Given this list of marker genes TXNRD2, TNFRSF11A, SLC16A1, MC2R, MRAP, PCSK1, HNF1A, PTH, CLDN16, POGZ, VDR (vitamin D receptor), TBCE, STX16, POMC, FAM111A, GCK, CYP2R1 (cytochrome P450 family 2 subfamily R member 1), UCP2, STAR, ABCC8, NNT, PROP1, TANGO2, SLC37A4, GATA3, GMPPA, SLC25A36, KCNJ11, GNAS, TRAPPC11 (NCBI Gene Id 60684), GCM2, INSR, CYP27B1, TBX19, AKT2, GLUD1, HADH, AAAS (NCBI Gene Id 8086), here is a description of the gene set: A seizure that occurs in the context of a brain insult (systemic, toxic, or metabolic) and may not recur when the underlying cause has been removed or the acute phase has elapsed. Human Gene Set: HP_SYMPTOMATIC_SEIZURES Symptomatic seizures species: Homo sapiens